The following is a description of a gene set: from publication Chen Y, Wang X (PMID 31504780) Genes predicted to be targets of miRBase v22 microRNA mmu_miR_1894_3p in miRDB v6.0 with MirTarget v4 prediction scores > 80 (high confidence targets). species: Mus musculus Mouse Gene Set: MIR_1894_3P, and this is the list of marker genes: Fgf1, Dhh, Hoxc4, Mettl8, Elovl5, Slc39a13, Kctd3, Rab43, Lpp, Cnot7, Zswim8, Oard1, Zfp493, Pabir1, Ints14, Nptx1 (NCBI Gene Id 18164), Vsx1, Rpgr, Bmal1, Ripor1 (NCBI Gene Id 75687), Slamf1, Krtap26-1 (NCBI Gene Id 69533), Dip2b, Arf4, Yars1, Eif4g2, Kif5b, Adtrp, Syn1, Glipr1l2, Rsbn1, Zscan10, Tbc1d22b, Arid4a (NCBI Gene Id 320602), Vapa, Tbx6, Btbd1, Grpel1, Acox2, Zfp882 (NCBI Gene Id 594836), Teddm1b, Cfap43, Gli2, Syt2, Rnf38, Cers4, Rab1a